Given this list of marker genes FBXO32, SERPINB2, SPINK5, S100A9, GPR160, SAMD9, NR1D1, CERS3, CST6, B3GNT8, SRGAP1 (NCBI Gene Id 57522), GRAMD2B, MGLL, FOSL2, PSCA, SMIM5, SFN, IRAG2, ASS1, OAS2, IFI16, GDPD3, VLDLR, GAN, CSTA, CAPNS2, PADI1, CDKN2B, PTK6, IQANK1, FUT3, EPS8L1, BMAL2, KANSL1-AS1, APOD, BICDL2, ATG9B, SRPX2, EHF, ACHE, MYZAP, ZNF185, PRRG4, SPRR2A, NMRK1, KRT23, RHOV, C15orf48 (chromosome 15 open reading frame 48), S100A4, MIR200CHG, TMEM184A, TP53INP2, GBP3, HECA, OAS1, B3GALT4, ADGRF1, TNFSF10, SPRR3, CNGA1, TICAM1, GGT6, ANXA1 (NCBI Gene Id 301), SPNS2, OSBPL3, ZNF57, ARRDC4 (NCBI Gene Id 91947), TMEM127, PLAAT4, TTC9, TINCR, CDKN1A, KRT16, LINC00278, MIR4435-2HG, PHLDA3, LNCTAM34A, ZFY-AS1, NCCRP1, SERPINB5, SBF2-AS1, DDB2, SCEL, CTSV, IL1RN, MX1, EPHX3, SYTL2, RHCG, SERPINB7, LINC02303, MAB21L4, MT1E (NCBI Gene Id 4493), LCN2, BARX2, GNG4, RNF39, SLC15A2, ALDH1A3, MUC20, IL36RN, TMPRSS4, GBP2, NABP1, FRMD6, CEACAM6, FUT6, PLD1, MAL, LYPD2, ZNFX1, LGALS9, IL10RB, CRYAB, CIMAP1B, MUC4, MEIS1, DUSP5, CYTOR, VSIR, PLAC8, PKP1, ABO, SRD5A3, OPTN, UACA, HPGD, PHLDA1, VGLL1 (vestigial like family member 1), LYST, MUC21, ST6GALNAC1, SCNN1A, DUOX1, COMTD1, TMEM40, GRAMD1C, SNX8, ZFYVE1, DEFB1, C15orf62, SAMHD1, TMEM117, A2ML1, PITX1, BNIPL, ZNF750, CPPED1, NRG4, S100P, TSPAN1, MOSPD1, CAMK2N1, APOBEC3C, SLPI, TGFA, CAB39L (calcium binding protein 39 like), EHD3, ARHGAP27, SLC45A4, RRAGD, ANKRD13A, ZNF554, LRATD1, B4GALT1-AS1, IFI6 (NCBI Gene Id 2537), PRSS27, RECQL5, ZNF524, LNX1, NECTIN4, IER5, TM4SF1, SKAP2, TMPRSS11B, IRF5, PLEKHG6, RNASEL, DHX58, CYSRT1, CDC42EP5, RNF223 (ring finger protein 223), EVA1C, SDCBP2, PLEKHF1, IFI27, TMPRSS11E, TYMP, ABLIM3, LINC01269, FNBP1, TNFRSF14, GNA15, HSPB8, SMPDL3A, GRHL1, HMOX1, EMP1, KRT78, BATF, MUC15, TRIM16 (tripartite motif containing 16), RARB, FDXR, DAPP1, KRT15, ITGB8, PIK3IP1, H4C8, GPR87, PLB1, IL34, CCDC69, LYPD3, B3GNT3, FAM25A, SP6, USP6NL, GCNT3, PHLDA2, KRT13, CRYBG2, PYGL, CD68, KRT7, ARAP2, DENND2C, IVL, ALS2CL, H2BC4, F3, ISG15, NEBL, AMN, APOBEC3A, FAM3D, KLC3, H2BC5, ZSWIM4, MPZL3, PRDM1, TUFT1, TCP11L2, RUNX2, TPCN1, TRIM29, RDH13, GNG12, ECM1, DOCK8, C6orf132, KRT80, ABCG1, H4C14, FAM83A, SMIM22, PAX9, CALML3, RAB27B, KRT4, LINC01816, RND3, APOBEC3B, C15orf39, UPK1B (uroplakin 1B), CLDN1, here is a description of the gene set: Human Gene Set: HE_LIM_SUN_FETAL_LUNG_C1_SQUAMOUS_CELL studied in species Homo sapiens from publication He P, Lim K, Sun D, Pett JP, Jeng Q, Polanski K, Dong Z, Bolt L, Richardson L, Mamanova L, Dabrowska M, Wilbrey-Clark A, Madissoon E, Tuong ZK, Dann E, Suo C, Goh I, Yoshida M, Nikolić MZ, Janes SM, He X, Barker RA, Teichmann SA, Marioni JC, Meyer KB, Rawlins EL (PMID 36493756) Squamous